The following is a description of a gene set: Reactome Pathway: RHO GTPases activate IQGAPs electronically inferred by orthology from the curated human pathway part of: RHO GTPase Effectors This event has been computationally inferred from an event that has been demonstrated in another species.<p>The inference is based on the homology mapping from PANTHER. Briefly, reactions for which all involved PhysicalEntities (in input, output and catalyst) have a mapped orthologue/paralogue (for complexes at least 75% of components must have a mapping) are inferred to the other species. studied in species Mus musculus, and this is the list of marker genes: Tuba3b, Tubb6, Men1, Tuba4a, Tuba1c, Tubb4a, Tubb4b, Tubb2b, Cdc42, Tuba8 (NCBI Gene Id 53857), Calm1, Tuba1b, Ctnnb1, Tubal3, Tuba1a, Cdh1